Given this list of marker genes PNKD, HSPG2, TPM2, GBA1, SF3B4, CLPB, MYMK, MYH8, PRRT2, COL2A1 (collagen type II alpha 1 chain), AHDC1 (NCBI Gene Id 27245), EDNRA, CRLF1, KCNC2, LIFR, here is a description of the gene set: species: Homo sapiens Human Gene Set: HP_TRISMUS Trismus Limitation in the ability to open the mouth.